The following is a description of a gene set: species: Homo sapiens Striated muscle contraction pathway Human Gene Set: WP_STRIATED_MUSCLE_CONTRACTION_PATHWAY, and this is the list of marker genes: TTN, DES, ACTN2, TPM3, MYBPC2, TNNC2 (NCBI Gene Id 7125), TMOD1, ACTC1, MYH6, MYL1, ACTA2, TPM4, MYBPC1, TNNT3, ACTG1 (actin gamma 1), TNNI1 (NCBI Gene Id 7135), TNNI2, VIM, MYOM1, MYL2, MYBPC3, MYH3, MYL4, DMD, MYL3, TPM2, TCAP, MYL9, TNNT1, MYH8, TNNT2, ACTN3, TNNI3, ACTA1, TPM1, ACTN4, NEB, TNNC1